Given this list of marker genes GRN, DNAJB2 (DnaJ heat shock protein family (Hsp40) member B2), METTL21A (NCBI Gene Id 151194), PDCL3, POFUT2, DNAJB1, SNRNP70, HSPA5, BAG5, PDCD5, here is a description of the gene set: Human Gene Set: GOBP_REGULATION_OF_PROTEIN_FOLDING studied in species Homo sapiens Any process that modulates the frequency, rate or extent of protein folding.